The following is a description of a gene set: Mouse Gene Set: TABULA_MURIS_SENIS_LARGE_INTESTINE_LARGE_INTESTINE_GOBLET_CELL_AGEING species: Mus musculus from publication Tabula Muris Consortium (PMID 32669714), and this is the list of marker genes: Car1, Cops5, Pglyrp1, Tagln2, 1810065E05Rik, Dynll2, Ndufv3, Ubb-ps, S100a11, Vsig2, Fdft1, Uqcrq, Gipc1, Bad, Ceacam10, Reep5, Dhrs7, Tcf7l2, Cox7a2l, Serhl (serine hydrolase-like), Arpc1b, Tmem160, Sumo1, Ndufs2, Mrps28, Yipf1, Arrdc1, Npc2, Tsc22d1, Ap2s1, Faap20, H2az2, Cuedc2 (NCBI Gene Id 67116, CUE domain containing 2), Atp6v1f, Bcl7c, Psmc5, Ptms, Nme2, Sdhc, Ech1, Ifi27l2b, Trappc2l, Pop5, Ndufs6, Pfdn2, Manbal, Mrpl23, Bscl2, Fuca1, Lamtor4, Fdps, Fth1, Atp5mf, Nupr1, Cyba, Ramac, Psmb2, Arf5, Ndufa13, S100a16, Snw1, Tpi1, H13, Mrpl12, Lamtor1, Cela1 (chymotrypsin-like elastase family, member 1), Pafah1b3, Psap, Ppp1r1b, Tmem97, Eif6, Gadd45b, Gjb1, Tmed10, Ybx1, Clps, Pin1, Atp5f1c, Mrps24, Psma2, Smim6, Sec11c, Serinc2, Mdh1, Ociad2, Ssbp4, Ubb, Pfn1, Tpsg1, Cdk2ap2, Rps24 (ribosomal protein S24), Ndufb8, Polr2e, Cltb, Cdc37, Ift20, Abhd17a, Naxe, Cst3, Plekhj1, Psmb4, F11r, Grpel1, Mrps10, Stk16, Rpl13a, Rplp1, Clic4 (chloride intracellular channel 4), Sec61g, Gtf2a2, Sdhd, Dnlz, Tmem222, Alg5, Rpl9, Psma3, Etfb, Tpd52l2, Creld2, Cox6b1, Chmp2a, Clic1, Sec13, Angptl4, Fbl, Akt1s1, Cisd1, Cenpx, Mgst2, Atp5po, Anapc16, BC031181, Mri1, Nfu1, Gstm5, Guk1, Rpl7a, Htatip2, Copz1, Lamtor2, Rnasek, Endog, Gmds, Tbcb, Map2k2, Rps7, Bet1l, Akr7a5, Mrpl14, Psmc2, Tex261, Ndufb9, Erp29, Aqp1, Tomm6, Cox4i1, Creb3, Eif3k, Ppib, Psmd4, Dhrs4, Surf1, Tmsb4x, Cgref1, Atf4, Dtymk, Zg16 (zymogen granule protein 16), Gadd45g, Timm13, Atp5pf, Rpl14, Tmem205, Wdr89, Rpl36al, Selenom, Rps6, Calm3, Ddx39b, Ddrgk1, Ciao2a, Snrpd3, Spr, Chchd10, Sh3bgr, Laptm4a, Acp5, Mrps16, Cfl1, Mdh2, Emc10, Tmem219, Tomm40, Idh2, Spint2, Swi5, Aamp, Ddt, Pycard, H3f3b, Rab5c, Rex1bd, Lrrc26, Mgst3, Ccnd2, Fermt1, Rpl18, Gm1123, Hypk, Trappc6b, Noxo1, Elovl1 (ELOVL fatty acid elongase 1), Vdac2, Kdelr1, BC004004, Serf2, Ndufc1, Mkrn2os (NCBI Gene Id 70291), Ten1, Tmem9, Qdpr, S100a13, Nedd8, Pcbd1, Wbp1, Eif2b2 (eukaryotic translation initiation factor 2B, subunit 2 beta), Nans, Sfxn1, Szrd1, Tmem11, Ppp4c, Ffar2, Plaat3, Mrps18a (NCBI Gene Id 98069), Fkbp11, Smim22, Cope, Lman2, Gabarapl2, Acot7, Ndufb10, Ndufs7, Fxyd3, Hsp90ab1, Ucp2, Ormdl2, Ccnd1, Selenow, Sumo3, Psmb6, Hes6, Rpl27a (ribosomal protein L27A), Tspan1, Mrpl57, Cyb5r3, Aga, Btf3, Jtb, Ntpcr, Emc4, Vcf1, Tle5, Tmed9, Oaz1, Ssr2, Babam1, Smim14, Ccs, Psmd8, Chchd2, Ptpmt1, Atox1, Dmac1, Gstt2, S100a1, Ppp1ca, Ssr4, Acp1, Tuba4a, Sfn, Sod2, Cox6a1, Gsto1, Fam3d, Ndufa12, Arf1, Rpl13, Naa10, Cib1, Mpdu1, Car2, Hsbp1, Tecr, Ppp1r2, Tmem176b, Aarsd1, Scand1, Rpl8, Nhp2, 2610528J11Rik, Ly6e, Hoxaas3, Aup1, Rps13, Rplp0, Mtch2, Uqcrh, Rpl24, Tmt1b, Psma6, Slc25a3, Ubl7, Ftl1, Bri3, Nfic, Cyp2c55 (cytochrome P450, family 2, subfamily c, polypeptide 55), Gadd45gip1, Scp2, Sin3b, Ptma, Degs2, Prelid3b, Fbp2, Rps11, Micos10, Psenen, Cd63, Mpv17l2, Scgb2b7, Ndufb11, Iscu, Atp5mg, Cycs, Nop10, Suclg1 (succinate-CoA ligase, GDP-forming, alpha subunit), Sec11a, Chd4, Dbi, Tmem238 (transmembrane protein 238), Gstp1, Cotl1, Pcbd2, Ccdc107, Eif3i, Ndufs3, Sdf4, Echs1, Rpl17, Psmb1, Rps20, Capzb, Mlf2, Prdx5, Dctn3, Tmem59, Nudt22, Mecr, Arpp19, Rhoc, Gcg, Tmem176a, Arpc3, Mrps11, Spcs1, Ubxn1, Gatd3a, Rer1 (NCBI Gene Id 76102), Emg1 (NCBI Gene Id 14791), Ntmt1, Sec61b, Exosc7, Fkbp8, Fuom, Rnaset2b, Ssna1, Cbfa2t3, Snrpb, Ndufa8, Elof1, Vkorc1, Ndufb7, Cdc123, Ldha, Zfand2b, Sf3b5, Eif3h, Ier2, Rpl11, Gstm1, Gapdh, Acta1, Ufc1, Mrpl28, B2m, Fkbp2, Calm2, Tmem45b, Psmb5, Smarcb1, Plp2, Syf2, Cryl1, Sdcbp2, Cracr2b, Smim20, Eif3f, Acot13, Abhd11, Tpgs1, Gnb2, Stap2, Hoxb13, Zfpl1, Edf1, Ranbp1, Klf5, Gm6402 (NCBI Gene Id 639398), Rps18, Rpl3, Tmem147, Atp5mc2, Rab3d, Mpi, Mrpl2, Rasl12, Smco4, Cyb5a, Samd4b, H1f2, Atp2c2, Aurkaip1, Kbtbd8, Ppdpf, Atp5pb, Polr1d, Fabp2, Wdr18 (WD repeat domain 18), Naa38, Arfip2, Ctsh, U2af1 (NCBI Gene Id 67034), Fam98c, Dpm2, Sil1, Naxd (NAD(P)HX dehydratase), Mrps34, Ier3, 2310011J03Rik, Hint2, Commd9, Mrpl20, Snrnp70, Aldh2 (NCBI Gene Id 11669), Mrpl30, Plet1, Ifitm2, Rpl18a, Mydgf, Tmem234, Rpl28, Gm14207, Hilpda, Ndufa7, Smdt1, Uqcc3, Rps5, Ube2v1, Ndufa2, Ctnnbip1, Ehd4, Arpc4, Mpc1, Rnase4, Bccip, Slc35b1, Coq9, Pdzd11, Fam32a, Nudt14, Tma7, Bola1, Coa3, H2-T23, Rpl19, Prr13, Rpsa, Bag1, Tmbim6, Nfkbib, Cnpy2, S100a14 (S100 calcium binding protein A14), Taf9, Psmc4, Chmp4b, Rbp4, Rps9, Prss32, Urah, Rpl6, Mea1, Ifi27, Spag7 (NCBI Gene Id 216873), Ebp, Tspo, Srsf5, Kcne3, Atp5mc3 (ATP synthase membrane subunit c locus 3), Gpx1, Dusp1, Pgls, Cdc42ep5, Tcf7l1, Mif, Hint1, H1f0, Sem1, Pfdn6 (NCBI Gene Id 14976), 2510002D24Rik, Gstm2, Ccdc124, Smim30, Atg3, Lypla2, Gpx4, Gabarap, Mrps12, Eif3g, Antkmt, Phldb3, Pla2g10, Pllp, Tmsb10, Banf1, Exosc5, Tax1bp1, Tubb4b, Ramp1, Cd9, Gfus, Wdr83os, Mag, Smagp, Rpl35, Itm2c, Mien1, Cisd3, Rps3a1, Eny2, Skic8, Ppif, Use1, Rps3, Map1lc3b, Rab2a, Agr2, Rabac1, Alad, Yipf3, Cox8a, Lage3, Sh3bgrl3, Calr, Rbm3, Rbm8a, Slc25a11, Cd151, Prelid1, Mcrip2, Rbm25, Lamtor5, Hmgcl, Pla2g2a, Ostc, Rps4x, Trappc6a, 3110040N11Rik, Sdf2l1, Dpm3, Gstp2, Calm1, Prx, Mpc2, Mrpl51, Znhit1, Eif5a, Ndufa10, Cirbp, Tcea3, Prss8, Krt19, Commd6, Rnf5, Jund, Psmd7, Akr1a1, Ndufv2, Tmem208, Rpl27, Rpl10a, Rpl10, Atp5mc1, Csnk2b, Psmb7, Park7, Dynlrb1, Uqcr10, Sycn, Tmem14c (NCBI Gene Id 66154), Srsf7, Tmed4, Vamp8, Ang (NCBI Gene Id 11727), Phf5a, Crip1, H2-D1, Atp6v0b, Tm2d2, Snrpc, Arhgdia, Qsox1, Eef1d, Mettl26, Phpt1, Pdcd6, Dap, Anapc11, Mrpl58, Hagh, Dcxr, Rps2, Bloc1s1, Cldn3, Snrpa, Txn2 (thioredoxin 2), Serbp1, Ndufs4, Ctsz, Txn1, Rps14, Ctsb, Ppa1, Trappc3, Vps72, Ap1s1, Mptx1, Ifi30, Fam3b, Mrpl43, Adrm1, Lsm2, Tpt1, Tm2d3, Cuta, Yif1a, Krtcap3, H2-K1, Ttr, Pmvk, Gpx2, Rnf7, Emc7, Ndufa11, Gmppb, 2310039H08Rik, Pts, Unc50, Gipc2, Vps28, Pgd, Hsd17b10, Txndc12, Eef1g, Nabp2, Atraid, Pdrg1, Cox5a, Hmg20b, Bsg, Pfdn1, Tmbim4, Nfkbia, Grcc10, Rrp1, Mob2, Mospd3 (NCBI Gene Id 78094), Ethe1, Nme1, Cd81, Phb2, Tmed3, Upb1, Myl6, Iigp1, Tmem109, Rab25 (NCBI Gene Id 99846), Rac1, Pomp (proteasome maturation protein), Ptgr1, Inafm1, Ppy, Foxp4 (forkhead box P4), Pold4, Pkm (NCBI Gene Id 18746), Gnb1, Atp5f1d, Cdo1, Hacd2, Prrg2, Syt7, Ypel3, Guca2b, Atg101, Irf8, Higd2a, Tmem141, Rps27a, Hsd17b8, Drap1, Dnajc3, Srm, Vps25, Cd82, Jagn1, Mvb12a, Npdc1, Psma7, Atp5if1, Rps10, Manf, Itpa, Ube2l3, Ppp1r11, Cldn14, Tex264, Scamp3, Rpl4, Trim46, Wbp2, Nectin2, Stub1, Fis1, Isg20, Tst, Snrpd2, Txnl4a, Selenos, Brk1, Cdpf1 (NCBI Gene Id 72355), Acot8, Psmb3, Ndufs8, Atp5pd, Psmd13, B3gat3, Syngr2, Cdx1, Timm17b, Lgals9, Erh, Micos13, Lsm4, Ptov1, Rplp2, Carhsp1, Sf3b2, Klk1, Krtcap2, Tstd1, Trappc1, Slc25a5 (NCBI Gene Id 11740), Commd4, Zmat5, Polr2g, Slc50a1, Pgp, Srp9, Pou2af1, Elob, Shisa5, Ube2m, Pebp1, Sar1b, Ppp1r14d, Bbln, Mrpl17, Ndufb6, Selenok, Bcat2, Dad1, Map1lc3a, Gale, Pfdn5, Psmc3, Cox14, Creb3l1, Gng11, Sft2d1, Mrpl21, Txndc17, Sri, Atp6v1g1, H2aj, Zfp330, Cmtm8